The following is a description of a gene set: studied in species Homo sapiens Human Gene Set: GOMF_SUGAR_TRANSMEMBRANE_TRANSPORTER_ACTIVITY Enables the transfer of a sugar from one side of a membrane to the other. A sugar is any member of a class of sweet, water-soluble, crystallizable carbohydrates, which are the monosaccharides and smaller oligosaccharides., and this is the list of marker genes: SLC2A10, SLC45A2, SLC5A4, SLC2A12, SLC2A2, SLC2A3, PPBP, SLC5A2, SLC2A1, SLC50A1, SLC2A9, SLC23A2, SLC2A5, SLC2A8, SLC2A11, SLC2A6, SLC2A14, SLC5A3, SLC5A11, SLC5A9, SLC45A3, SLC5A10 (NCBI Gene Id 125206), SLC5A1, SLC23A1, SLC2A7, SLC2A4, SLC45A1